The following is a description of a gene set: A bilateral form of agenesis of the kidney. Bilateral renal agenesis species: Homo sapiens Human Gene Set: HP_BILATERAL_RENAL_AGENESIS, and this is the list of marker genes: HS2ST1, GFRA1, NADSYN1, FREM2, ROBO1, GLI3, ITGA8 (NCBI Gene Id 8516), GRIP1, KIF14 (kinesin family member 14), FGF20